The following is a description of a gene set: Any process that increases the frequency, rate or extent of peptidase activity, the hydrolysis of peptide bonds within proteins. Human Gene Set: GOBP_POSITIVE_REGULATION_OF_PEPTIDASE_ACTIVITY studied in species Homo sapiens, and this is the list of marker genes: VCP, MBP, SERPINB3, CR1, PRSS22, SEMG1, SEMG2, GRN, RCN3, TANK, VSIR, PRELID1, PSENEN